Given this list of marker genes Ro60, Rad23a, Cirbp, Nscme3l, Zbtb1, Bak1, Uaca, Dcun1d3, Polh, Ercc5, Col6a2, Mmp1a, Crip1, Hyal2, Il12b, Egfr, Ercc2, Sde2, Ino80, Eif2ak4, Hyal3, Ercc6, Mapk9, Ei24, Ddb1 (damage specific DNA binding protein 1), Timp1, Bcl3, Ptprk, Dtl, Col6a1, Ube4b, Ddb2, Map4k3, Ube2a, Men1, Xpa, Prkcd, Rad23b, Rnf168, Tipin, Mme, Col6a3, Nlrp1b, Mmp1b, Rpain, H2ac25, Rbx1-ps, Tmem161a, Polk, Msh2, Mmp3, Casp7, Mdm2, Map2k7 (mitogen-activated protein kinase kinase 7), Pold1, Atr, Ercc3, Pcna, Dhx36, Elane, Ccar2, Eif2s1, Aqp1 (NCBI Gene Id 11826), Pbk, Ep300, Smpd1, Rbx1, Rev1, Opn5, D7Ertd443e, Poli, Pclaf, Primpol, Usp1, Mapk11, Sdf4, Nfatc4, Tyr, Actr5, Mapk8, Ivl, Prkaa1, Pmaip1, Ppid, Bax, Ube2b, Fech, Crebbp, Rad18, Cdkn1a, Cdkn2d, Parp1, Yy1 (YY1 transcription factor), Opn3, Opn1sw, Bmf, Casp3, Noc2l, Sirt6, Casp9, Ercc4, Stk11, Ercc1, Trim32, Trp53inp1, Mettl3, Cul4b, Trex1, Ccnd1 (cyclin D1), Msh6, Bcl2, Nlrp1a, Trp53 (NCBI Gene Id 22059), Gpx1, Pola1, Brsk1 (NCBI Gene Id 381979), Brca2 (breast cancer 2, early onset), Cdc25a, Npm1, Usf1, Pik3r1, Cers1, Agap3, Trp53i13, Mapk14, Map3k4, Hmgn1, Uvssa, Map3k20, Rela, Nsmce3, Ruvbl2, Nedd4, Il12a (NCBI Gene Id 16159), Sirt1, Rhno1, Hus1, Usp28 (NCBI Gene Id 235323), Xpc, Rhbdd1, Gnat2, Ddias, Cul4a, Mfap4, Mmp9, Hyal1, Pold3, Cops9, Sprtn, Mc1r, Ercc8, Pierce1, Aurkb, Zranb3, Cryaa, Cat, Mmp2, Pml, Rpl26, Wrn, Akt1, Fbxw7, Kdm1a, Mapk13, N4bp1, Triap1, here is a description of the gene set: Mouse Gene Set: GOBP_RESPONSE_TO_UV studied in species Mus musculus Any process that results in a change in state or activity of a cell or an organism (in terms of movement, secretion, enzyme production, gene expression, etc.) as a result of an ultraviolet radiation (UV light) stimulus. Ultraviolet radiation is electromagnetic radiation with a wavelength in the range of 10 to 380 nanometers.